The following is a description of a gene set: species: Homo sapiens Human Gene Set: HP_ABNORMAL_CELLULAR_COMPOSITION_OF_BRONCHOALVEOLAR_FLUID Abnormal cellular composition of bronchoalveolar fluid Deviation from the commonly in healthy people observe cellular distribution. Normal ranges are macrophages over 80%, lymphocytes less than 15%, neutrophils less than 3%, eosinophils less than 0.5%, mast cells less than 0.5%., and this is the list of marker genes: SFTPC, CAPNS1 (NCBI Gene Id 826), SFTPA2, TERT, SFTPA1, BTNL2, HLA-DRB1, COPA, MUC5B, NKX2-1